Given this list of marker genes ALG6, SLC30A9, CPEB3, BACH2, ABCA5, GOLIM4, RIT2, GGCT, LARP4, RXFP1, COA3, CYCS, KDM5A, CCNYL1, SPATA9, PCGF5, NKRF, USP53, ZNF385C, MED14, KLF13, MAP3K4, CREB1, TCF7L2, CNST (consortin, connexin sorting protein), TMBIM6, MED13, SGTB, HMGB3, TAF1, MYCBP2, RELL1, MRPL1, TM2D1, YWHAZ, RARB, SEMA4B, ASPH, VBP1, TTYH3, DNAJB1, NUFIP2, HAPSTR1, SPARCL1, CDK5R1, ZNF17, EP300, EIF4H (NCBI Gene Id 94573), KAT2B, SLC30A4, SCLT1, TXNRD1, UBE3C, DPP10, ZC3H14, HS2ST1, RBM17, TLR8, RCOR3, LGR4, DNM3, TMEM108, SCRIB, C9orf72 (NCBI Gene Id 73205), GABPA, NUDT4, THADA, TBX3, GPR85, XPR1, SP3, SKP1, KLF4, VPS13A, METTL13, ARHGAP17, PKDREJ, SMARCC1, SAMD4A, RBPJ, SS18, GPANK1, SERINC3, SRP19, IL7R, ARID1A, TLE1, PTP4A1, BROX, ASB8, C5orf22, HECA, CPEB2, NFAT5, MBNL1, SLC25A4, NUCKS1, PAQR5, SAMD12, SLC17A7, ASCL1, LONRF3, MIEF2, ARL15, NR3C1, FAM114A2, RTN4, TENT5C, BMPR1A, CKAP2, PPIL3, GPR158, ESS2, GSK3B, EIF5A, TP53INP1, NR2F2, OSBPL6, CENPP, RPGRIP1L (NCBI Gene Id 23322), STX7, ELOC, SOBP, ZIC2, DDX3X, PTBP3, SYNRG, TAF12, MYOG, ACVR1C, EIF4G2, EXTL3, JARID2, INPP4A, IGSF10, ZFAND4, WNT5A, NAA35, PAK1, MRPL47, EEF2K, CEP76, PAK2, PGM2L1, SMG7, ACSL1, MYB, RBM24, MLLT10, IGF1, NTS (NCBI Gene Id 96646), UBE2E2, ATP1B3, NDFIP2, CDK12, FOXO1, REPS1, LYPLA2, VAPA, G2E3, PPARGC1A (NCBI Gene Id 10891), FAM120A, SMAD2, TMX3, AGPS, SLC31A1, FBLN2, TMEM158, TMX4, GFM1, GADL1, SLC24A1, LRCH1, NCAPG2, SNX2, CAB39, OTX2, PDCD6IP, ATG7, MRPL10, NCAPG, UBA2, IRF4, RTN1, TIAM2, ROBO2, GAN, GOPC, NCOR1, SERP1, MYO9B, BAIAP2, INTS6, SCN9A (sodium voltage-gated channel alpha subunit 9), DSG1, ZBTB34, MSRB3, SPIN1 (spindlin 1), HLCS, BIRC6, HMGN3, THAP12, PRDM1, FAM124B, CEP135, AP4E1, MKRN1 (makorin ring finger protein 1), AFG1L (AFG1 like ATPase), NDUFB3, GRM2, ATAD2B, CAPRIN1, AMD1, PUM2, MELK, MAPK8, CNN2, GRK3, TBCEL, GID4, SECISBP2, ASAP2, TBX18, WTAP, EDAR, INO80D, LRRC3B, GUCY1A2, NRCAM, RICTOR, LIFR, TRMT10A, CLDND1, here is a description of the gene set: from publication Chen Y, Wang X (PMID 31504780) Genes predicted to be targets of miRBase v22 microRNA hsa-miR-497-3p in miRDB v6.0 with MirTarget v4 prediction scores > 80 (high confidence targets). studied in species Homo sapiens Human Gene Set: MIR497_3P